The following is a description of a gene set: Mouse Gene Set: chr1E3 studied in species Mus musculus, and this is the list of marker genes: Gm29383, Cxcr4, Rab3gap1, Lct, Ubxn4, Dars1, Ccnt2, Lypd1, Gm23902, Tmem163, R3hdm1, Nckap5, Mcm6, Mir128-1, 2900009J06Rik, Mgat5, Rpl28-ps1, Acmsd, Gm8451 (NCBI Gene Id 675905), Map3k19, Gm25384, Gm23370, Gm6170, Zranb3, Gm5261, Gm28800, 4930599A14Rik, Gm23734 (predicted gene, 23734)